The following is a description of a gene set: species: Mus musculus Mouse Gene Set: chr16B5, and this is the list of marker genes: Plcxd2, Btla, Gm8670, Cd47, Tagln3, Retnlg, Mir6363, 4930405D01Rik, Gm18694, Gm32431, Gm17804, Abhd10, Gm6912, Nectin3, 4930542D17Rik, 1700116B05Rik, Gm17900, 4930404A05Rik, Cd200r3 (CD200 receptor 3), Gm22576, BC016579, Gm16011, Gm6914 (predicted gene 6914), Ccdc54, Slc35a5, Phldb2, Gm5407, Gm6931, Gm8824, Gm6030, Gm7204, Gm22459, Retnlb, Gm6903, Cd200l1, Gm9575, Gm7275, Cd200, Gm50487, Cblb, Trat1, Ahcyl, Myh15, Gm4802, Gm5406, Gm15638, Slc9c1 (solute carrier family 9, subfamily C (Na+-transporting carboxylic acid decarboxylase), member 1), Gm29686, 6430553K19Rik, Ccdc80, Dubr, G730013B05Rik, Gcsam, Cd96, Alcam, Dppa2, Gm6767, Bbx, Tmprss7, Dzip3, Gm15518, Atg3, Ift57 (NCBI Gene Id 73916), Dppa4, Retnla, Gm25723, 1700026J12Rik (RIKEN cDNA 1700026J12 gene), Cip2a, Morc1, Gm5485, Gm18169, Cd200l2